Given this list of marker genes CYC1, UQCC1, MT-ND4, ECSIT, FXN, UQCRHL (NCBI Gene Id 440567), NDUFB10, NDUFB11, LYRM7, NDUFS5, MT-CO2, MT-CO3, UQCRH, SDHA, TTC19, UQCRFS1, COX8A, BCS1L, COX7B, SURF1, SLC25A12, NDUFA2, NFS1, COA3, NDUFB9, PET117, NDUFV3, HIGD1C, MT-CYB, MT-ND1, TMEM126A, COX7A2, MT-ND5 (NCBI Gene Id 4540), MT-ND3, TMEM126B, COQ10B, NDUFA10, NDUFAF5, COX17, ETFDH, LYRM2, HIGD1A, NDUFA3, DMAC1, PNKD, NDUFC2, NDUFB4, NDUFAF7 (NCBI Gene Id 55471), NDUFS7, NDUFB2, NDUFA8, HCCS, COX20, CYCS, ACAD9, COX8C, TACO1, NDUFA12, COX15, TMEM177, NDUFAF6, UQCRB, LYRM4, SLC25A22, COX6A2, NDUFA7, PET100, COX6B2, NDUFB7, MT-ND2, NDUFS6, TIMM21, NDUFB3, TRAP1, SCO1, ISCU, UQCC6, COX14, SDHD, UQCR10, NDUFB1, NDUFAF8, ETFA, UQCRC1, NDUFA6, NDUFA13, NDUFC1 (NCBI Gene Id 4717), SMIM20, COX4I2, SCO2, LETM1, COX6A1, COX7C, GOT1, UQCRC2, TIMMDC1, NDUFAF3, OXA1L, UQCRQ, SLC25A18, NDUFV2, UQCR11, NDUFS3, NDUFS4, NDUFV1, NUBPL, NDUFB5, NDUFAF4, COX5A, HSCB, HSPA9, MDH2 (malate dehydrogenase 2), NDUFAF1, ETFB, UQCC2 (NCBI Gene Id 84300), SDHB, COX19, NDUFA5, UQCC3, COQ10A, NDUFAF2, COX7A2L, COX16, NDUFS1, NDUFS2, COX5B, MDH1, COA5, CMC1, NDUFB6, COX6C, NDUFA11, COX4I1, COX7A1, GOT2, SDHC, COX11, MT-ND6, NDUFB8, TMEM223, NDUFS8, RAB5IF, PYURF (NCBI Gene Id 100996939), SFXN4, SLC25A11, UQCC5, HIGD2A, COX6B1, COA1 (NCBI Gene Id 55744), FOXRED1, NDUFAB1, COX18, NDUFA1, COXFA4, SLC25A13, NDUFA9, DMAC2, TMEM186, MT-CO1 (NCBI Gene Id 4512), here is a description of the gene set: Mitochondria are often described as the "powerhouse" of a cell as it is here that energy is largely released from the oxidation of food. Reducing equivalents generated from beta-oxidation of fatty acids and from the Krebs cycle enter the electron transport chain (also called the respiratory chain). During a series of redox reactions, electrons travel down the chain releasing their energy in controlled steps. These reactions drive the active transport of protons from the mitochondrial matrix, through the inner membrane to the intermembrane space. The respiratory chain consists of five main types of carrier; flavins, iron-sulfur centres, quinones, cytochromes (heme proteins) and copper. The two main reducing equivalents entering the respiratory chain are NADH and FADH2. NADH is linked through the NADH-specific dehydrogenase whereas FADH2 is reoxidised within succinate dehydrogenase and a ubiquinone reductase of the fatty acid oxidation pathway. Oxygen is the final acceptor of electrons and with protons, is converted to form water, the end product of aerobic cellular respiration. A proton electrochemical gradient (often called protonmotive force) is established across the inner membrane, with positive charge in the intermembrane space relative to the matrix. Protons driven by the proton-motive force, can enter ATP synthase thus returning to the mitochondrial matrix. ATP synthases use this exergonic flow to form ATP in the matrix, a process called chemiosmotic coupling. A by-product of this process is heat generation.<br><br>An antiport, ATP-ADP translocase, preferentially exports ATP from the matrix thereby maintaining a high ADP:ATP ratio in the matrix. The tight coupling of electron flow to ATP synthesis means oxygen consumption is dependent on ADP availability (termed respiratory control). High ADP (low ATP) increases electron flow thereby increasing oxygen consumption and low ADP (high ATP) decreases electron flow and thereby decreases oxygen consumption. There are many inhibitors of mitochondrial ATP synthesis. Most act by either blocking the flow of electrons (eg cyanide, carbon monoxide, rotenone) or uncoupling electron flow from ATP synthesis (eg dinitrophenol). Thermogenin is a natural protein found in brown fat. Newborn babies have a large amount of brown fat and the heat generated by thermogenin is an alternative to ATP synthesis (and thus electron flow only produces heat) and allows the maintenance of body temperature in newborns.<br><br>The electron transport chain is located in the inner mitochondrial membrane and comprises some 80 proteins organized in four enzymatic complexes (I-IV). Complex V generates ATP but has no electron transfer activity. In addition to these 5 complexes, there are also two electron shuttle molecules; Coenzyme Q (also known as ubiquinone, CoQ) and Cytochrome c (Cytc). These two molecules shuttle electrons between the large complexes in the chain.<br><br>How many ATPs are generated by this process? Theoretically, for each glucose molecule, 32 ATPs can be produced. As electrons drop from NADH to oxygen in the chain, the number of protons pumped out and returning through ATP synthase can produce 2.5 ATPs per electron pair. For each pair donated by FADH2, only 1.5 ATPs can be formed. Twelve pairs of electrons are removed from each glucose molecule;<br><br>10 by NAD+ = 25 ATPs<br>2 by FADH2 = 3 ATPs.<br><br>Making a total of 28 ATPs. However, 2 ATPs are formed during the Krebs' cycle and 2 ATPs formed during glycolysis for each glucose molecule therefore making a total ATP yield of 32 ATPs. In reality, the energy from the respiratory chain is used for other processes (such as active transport of important ions and molecules) so under conditions of normal respiration, the actual ATP yield probably does not reach 32 ATPs.<br><br>The reducing equivalents that fuel the electron transport chain, namely NADH and FADH2, are produced by the Krebs cycle (TCA cycle) and the beta-oxidation of fatty acids. At three steps in the Krebs cycle (isocitrate conversion to oxoglutarate; oxoglutarate conversion to succinyl-CoA; Malate conversion to oxaloacetate), a pair of electrons (2e-) are removed and transferred to NAD+, forming NADH and H+. At a single step, a pair of electrons are removed from succinate, reducing FAD to FADH2. From the beta-oxidation of fatty acids, one step in the process forms NADH and H+ and another step forms FADH2.<br><br>Cytoplasmic NADH, generated from glycolysis, has to be oxidized to reform NAD+, essential for glycolysis, otherwise glycolysis would cease to function. There is no carrier that transports NADH directly into the mitochondrial matrix and the inner mitochondrial membrane is impermeable to NADH so the cell uses two shuttle systems to move reducing equivalents into the mitochondrion and regenerate cytosolic NAD+. <br>The first is the glycerol phosphate shuttle, which uses electrons from cytosolic NADH to produce FADH2 within the inner membrane. These electrons then flow to Coenzyme Q. Complex I is bypassed so only 1.5 ATPs can be formed per NADH via this route. The overall balanced equation, summing all the reactions in this system, is<br><br>NADH (cytosol) + H+ (cytosol) + NAD+ (mito.) = NAD+ (cytosol) + NADH (mito.) + H+ (mito.)<br><br>The malate-aspartate shuttle uses the oxidation of malate to generate NADH in the mitochondrial matrix. This NADH can then be fed directly to complex I and thus can form 3 ATPs via the respiratory chain. The overall balanced equation is<br><br>NADH (cytosol) + H+ (cytosol) + FAD (inner memb.) = NAD+ (cytosol) + FADH2 (inner memb.)<br><br>Both of these shuttle systems regenerate cytosolic NAD+.<br><br>The entry point for NADH is complex I (NADH dehydrogenase) and the entry point for FADH2 is Coenzyme Q. The input of electrons from fatty acid oxidation via ubiquinone is complicated and not shown in the diagram. species: Homo sapiens part of: Aerobic respiration and respiratory electron transport Reactome Pathway: Respiratory electron transport